Given this list of marker genes SRGAP3, RNF138, ZNF385B, TAF4, ZRANB2, PATL1, DIRAS2, PTK2, USP42, SCRT1, LZTS1, TGFBR1, MTSS1, RAB1B, AGO1, CSNK1A1, SNRK, SERTAD2, MEF2C, HIF1A, CPLX1, B4GALT5, MOB1B, KCNMA1, IL6ST, LINC00315, PELI1, FNDC5, SDCBP, WAC, PHOSPHO1 (phosphoethanolamine/phosphocholine phosphatase 1), MYPOP, TRPM7, NUCKS1, ZNF236, STK35, ADCYAP1, MAT2A, CREB5, TBL1XR1, TOPORS, PHLPP2, ELK1, HNRNPA1, CPLX2, PITPNC1, DDX3X, PSIP1, MAPKBP1, CD47, SSR2, FKBP1A, POU2F3, SIAH1, SGMS1, WAPL, JAKMIP2, CHSY1, WSCD2, GRK5, GATA3, ATP2B2, DIP2C, ZNF322, BSN, NEURL1, ORMDL2, BCL11B, CALML4, PAK5, KCNAB3, SON, JAK2, RHO, MON1A, DTNA, ILRUN, ADO, MSL2, IGF2BP1, TRAPPC8, BTBD2, IDH3G, PGGT1B, CADM4, FOXN3, LIMK2, CTTNBP2, FCHO2, CUX2, GABRG1, SPOCK1, MYT1L, BACE1, GPM6B, ACVR1B, ZNF322P1, FOXO1, RARB, ZCCHC14, DRAM2, GGNBP2, SLC44A1, KPNA3, EPHA3, SP1, CCNG2, C3orf70, SSR1, TSC22D3, LMBRD2, SEC62, TMEM97, UBE3C, RNF152, PHTF2, PHLDB2, CCSAP, API5, GLRB, STAMBP, SOCS4, FRMD4A, ZBTB44, PELI2, GPR3, BZW1, MBD6, EVI5, GAS7, SFSWAP, NDRG4 (NDRG family member 4), NAGS, GPR85, FRK, ORC5, KCTD12, ALPK1, SYNGAP1, GOLGA7, TMEM168, NDFIP2, SNTA1, AEBP2, TLK1, RGL1, CRAMP1, SLC35F1, B4GALNT1, SLC39A13, SPINK4, BCL11A, KCND1, ANKRD40, PCYT1B, NEGR1, HIF1AN, TENT5A, ZBED4, WDR45B, HPS5, MIER3, BMPR1A, JDP2 (NCBI Gene Id 122953), SYT3, ARHGEF2 (Rho/Rac guanine nucleotide exchange factor 2), IGF2BP2, YBX2, ARHGEF6, DMRT1, KCTD1, TSEN54, SMC1A, FBXL16, CENPB, ELK3, LCP1 (NCBI Gene Id 3936), MKNK1, NUP153, RBAK, ATF3, ZNF385A, GABPB2, VLDLR, DDX3Y, ARHGAP6, NUDT4, ZNF362, SMURF2, GCC2, STX6, HOXA10, YTHDF3, NCKIPSD, MRAS, AKT3, RIMS2, DUSP5 (dual specificity phosphatase 5), DLG2, PPP1R12C, MTURN, ABCE1, SIRT1, MTMR12, MTDH, DPF1, ATP2B4, BMPER, PRKD3, THRB, SLITRK6, WASHC4, ARL6, VNN3P, HNRNPU, BTBD10, CHMP4B (charged multivesicular body protein 4B), CACNA1E, CREG1, ANK3, SEMA6D, PDE7B, CAPN15, SLC24A2, MYEF2, C6orf120, PAPOLA, PEDS1, BACH1, CIC, PTER, PLCG1, DLGAP2, DGKH, SLC9A9, MTUS1, BRWD1, STMN4 (stathmin 4), GRPEL2, QKI, PIM2, SP3, KALRN, LRRN1, LDLRAD2 (NCBI Gene Id 401944), RNF144A, SCN2B, RUNX1, ELOVL2, PHF20, TEFM, SHISA6, CCND2 (cyclin D2), TRIM23, FAM219A (NCBI Gene Id 203259), BCL9L (NCBI Gene Id 283149), ATP2B3, ARHGEF7, PDE8B, ENTPD7, ZNF143, VGLL4 (NCBI Gene Id 9686), NCOA1, ROCK2, RALBP1, SHISA7, TMEM9, PRUNE2, ANO4, SETD7, RPS6KB1, PPP6R3, LONRF1, C1orf198, CNTNAP1, ARHGEF4, CALN1, ARID5B, ZNF44, RAP2A, ATP6V1C2, TBK1, RNF43, ANXA7 (annexin A7), COL4A3, UBOX5, PDE4A, NEFM, PARL, ZSWIM4, BZW2, RARA, KLF4, RAPGEF6, DIS3L2, DAG1, INHBA, SLC25A5, PIK3R2, ZDHHC6, ENTPD4, MSX2, NR3C2, ST7L, SELENOH, CACNA1D, MAN1A1, PLCB1, STAT6, PPP1CC, YWHAG, HERC6, CPD, FRMPD4, JOSD1, SLC5A7, RGPD5, RPS29, USP15, ANGPTL2, BMPR2, TRPC1, ADAMTS9, ESRRA, EXTL2, ATG14, RASAL2, NBEA, PPP2R5C, CSNK1G1, SKI, ATP1B1, ZNF518A, KMT5C, AKR1A1, here is a description of the gene set: studied in species Homo sapiens Genes having at least one occurence of the motif AAGCCAT in their 3' untranslated region. The motif represents putative target (that is, seed match) of human mature miRNAs hsa-miR-135a and hsa-miR-135b (v7.1 miRBase). Human Gene Set: AAGCCAT_MIR135A_MIR135B